Given this list of marker genes Cenpq, Ttk, Bub3, Rcc2, Spdl1, Knl1, Ik, Trappc12, Aurkb, Cdk1, Snhg15, Zw10 (NCBI Gene Id 76189), Mtbp, Champ1, Zwilch, Kntc1, here is a description of the gene set: Mouse Gene Set: GOBP_PROTEIN_LOCALIZATION_TO_CONDENSED_CHROMOSOME A process in which a protein is transported to, or maintained in, a location within a condensed chromosome. studied in species Mus musculus